The following is a description of a gene set: An anomaly identified by motor evoked potentials (MEPs). MEPs are measured following single-pulse or repetitive transcranial magnetic stimulation and can be used for the assessment of the excitability of the motor cortex and the integrity of conduction along the central and peripheral motor pathways. Abnormal motor evoked potentials studied in species Homo sapiens Human Gene Set: HP_ABNORMAL_MOTOR_EVOKED_POTENTIALS, and this is the list of marker genes: ITPR1, NEFL, SACS, SLC33A1, KPNA3, UBAP1, CYP27A1, STUB1, GJC2, RTN2, CPT1C, WASHC5